The following is a description of a gene set: Abnormal columella morphology Human Gene Set: HP_ABNORMAL_COLUMELLA_MORPHOLOGY studied in species Homo sapiens A structural abnormality of the columella., and this is the list of marker genes: HIVEP2, NAA10, TBCD, ALG9, PIK3C2A, NALCN, ACTG1 (NCBI Gene Id 71), DNMT3A, RHOBTB2, THUMPD1, MAN2C1, PQBP1, H3-3B, TAF6, CKAP2L, POC1A, KDM5B, RPS6KA3, EP300, FLI1, ZEB2, RAC1, RYR1, EDEM3, MBD5, CWC27, TRIO, ZMIZ1 (zinc finger MIZ-type containing 1), CLP1, CDC42BPB, ATP6V1E1, ZSWIM6, LMBR1 (NCBI Gene Id 85501), CREBBP, CTCF, CHST14, GJA8, TRIP12, SCNM1, ZNF148, PCDHGC4, CTNNB1, TGDS, BICRA, ASXL3, GJA5, CEP295, RDH11, ERF, KNL1, SRCAP, AIMP2, SETD2, KDM3B, HNRNPH2, NOG, TEFM, PPP1R21, UBE2A (ubiquitin conjugating enzyme E2 A), GJA1, CENPF, MGAT2, ARSL, KMT2D, SMG9, TWIST1, PUM1, EXOSC2, SMARCA2, CLCN3, H4C5, HDAC4, KDM6A (lysine demethylase 6A), KCNH1, CAPN15, CNTNAP2, B3GLCT, ZFX, CDH11, CAPRIN1, KAT6A, TAF4, ACTB, THOC6, MAB21L1, ITCH, ALX4, KMT5B, RNU4-2, ATN1, SHH, AHDC1, AFF3, TSPEAR, FILIP1, HNRNPR, KCTD1, ALX3 (NCBI Gene Id 93575), LIFR, KMT2A, MADD, SOX11